Given this list of marker genes Wnk4, Wnk1 (WNK lysine deficient protein kinase 1), Atp1b2, Atp1b3, Dlg1, Wnk3, Wnk2, Atp1b1, here is a description of the gene set: studied in species Mus musculus Mouse Gene Set: GOBP_REGULATION_OF_POTASSIUM_ION_IMPORT Any process that modulates the frequency, rate or extent of potassium ion import.